Given this list of marker genes Tspoap1, Sts (NCBI Gene Id 20905), Stard3, Akr1b1, Hmgcs1, Cyp24a1, Dhcr7, Idi1, Slc27a2, Gc, Akr1c14, Srd5a1, Plpp6, Acot8, Cyp11b2, Ran, Slc51b, Hsd17b11, Hsd17b4, Hsd3b2, Hsd11b2, Nsdhl, Hsd3b4, Sqle, Abcb11, Baat, Tm7sf2, Acox2, Cyp19a1, Akr1d1, Osbp, Hsd17b3, Cyp39a1, Ch25h, Hsd3b8 (hydroxy-delta-5-steroid dehydrogenase, 3 beta- and steroid delta-isomerase 8), Cyp8b1, Idi2, Tspo, Akr1c18, Alb, Cyp7a1, Arv1, Cga, Dhcr24, Slco1a4, Hsd17b14, Pomc, Srebf2, Hsd17b1, Slc10a2, Cyp51, Akr1b7, Fdft1, Cyp17a1, Fdx2, Akr1b8, Akr1c21, Hsd3b5, Amacr, Cyp46a1, Serpina6, Osbpl2, Abcc3 (NCBI Gene Id 76408), Srd5a2, Fdxr, Fdx1, Stard3nl, Akr1c20, Ncoa1, Kpnb1, Osbpl6, Osbpl1a, Akr1c13, Pias4, Hsd3b9, Vdr, Akr1c6, Hsd17b2, Akr1b10, Lbr, Osbpl7, Slc27a5, Slc10a1, Fabp6, Nr1h4, here is a description of the gene set: studied in species Mus musculus This event has been computationally inferred from an event that has been demonstrated in another species.<p>The inference is based on the homology mapping from PANTHER. Briefly, reactions for which all involved PhysicalEntities (in input, output and catalyst) have a mapped orthologue/paralogue (for complexes at least 75% of components must have a mapping) are inferred to the other species. electronically inferred by orthology from the curated human pathway part of: Metabolism of lipids Reactome Pathway: Metabolism of steroids